Given this list of marker genes KCNB1, RAB6A, AP3S2, MITD1, EHD3, SYT7, SEC24C, MTMR2, BLTP3B, EXOC1 (exocyst complex component 1), EHD4, TRIM23, ARRB1, GH1, TMED5, RAB32, ITGA4, EIPR1, TXLNA, FCGRT, ABCA1, MGRN1, ZFYVE16, PKDCC, MBL2, SLC18A2 (NCBI Gene Id 6571), MAPK3, CALY, STBD1, PIP5K1A, CLEC10A, CLEC4M, CTNNB1, CAPN2, RAB5A, KIAA0319L, SNPH, MTMR9, CMTM6, RIN2, CALM2, ACSL3, GOLGA7, AP3S1, PDLIM7, PIKFYVE, GGA3, CSPG5, GRXCR1, CLCN2, ARL11, ITGAV, FCMR, NEDD4L, PLA2G4E, CD300LF, PRKCG, SYNGR3, GSG1L, INTU, BLZF1, RAB27B, SCAMP2, MON1A, UEVLD, IL4R, IL10RA, YIPF1, OTOF, SCAP, ACHE, OSBPL5, CFTR, PDPK1, ENPP1, SNX30, SNX6, SGSM3, TMCC1, NOTCH1, VPS35L (VPS35 endosomal protein sorting factor like), PRKCB, NSG2, CSK (NCBI Gene Id 1445), LRP4, CSNK1G3, SEPTIN4, SNCG (NCBI Gene Id 6623), GPR151, CD81, AP4B1, NCF4, BAIAP3, BECN1, MAPKAPK2, HPCA, ZFYVE9, CTTN, TMEM63B, RAB11FIP1, LIN7A (lin-7 homolog A, crumbs cell polarity complex component), ADGRE2, CBLB, YIPF6, ERO1B, YIPF7, KIF5A, BLOC1S5, NLRP5, GIT2, RAB13, USO1, FCGR2B, SYNRG, ANO6, SPHK1, RUBCN, PRKAR1B (protein kinase cAMP-dependent type I regulatory subunit beta), HSPG2, VPS13A, DOC2B, AP5S1, FUZ, COPB1, SV2A, MSN, GRK3, TREX1, SYNGR1, VTA1, TRAPPC3L, NCKIPSD, MBTPS1, RAB33B, CUX1, ARF3, PLIN3, STX1A, RAB39B, PLLP, SEC16B, RAB11B, FGR, M6PR, FNBP1, RAB9A, LEPROT, VPS26C, SNX5, SNAP91, SCARA3, PIK3CB, ANXA8, MIR27B, GATA2, VAMP4, NAPA, SIRPG, IFNG, GPC3, RAB40B, SNAPIN, SYT10, EPHA3, STXBP2, NCKAP1L, HEATR5A, TMED6, SLC48A1, LEPR, ATP6V1C1, AGAP2, AP1S3, RAPGEF4, SLC2A4, NEDD4, PTGDR, ARFGAP3, NLGN3, LRRTM2, SEC23IP, DENND1A, ACKR3, PACSIN1, NRG1, CLTA, SCARF1, SNX9, PGAP1, FERRY3, ACTB, NPY, HPS4, TVP23C, C4BPA, DRD2, VAMP7, LIPA, RASEF, PDCD6IP, CEBPE, SPHK2, DENND2A, GTF2H2, LIN7C, CHMP4B, SV2B, ATAD1, ANK1, PRKACA, BRSK1, CLCN3, TMEM50A, STEAP2, TGFB1, RAB31 (RAB31, member RAS oncogene family), RAB9B, RER1, PIP4P2, RAP1B, PLAA (NCBI Gene Id 9373), PCDHGA3, SOD1, CXCL16, DOC2A, DENND10, BET1, VPS37D, MYO1A, OPHN1, P2RY6, GGA2, FCGR1A, CEP19, SMCR8, DIAPH3, AP3M2, VPS50, CORO7, SEC24A, TAPBP (TAP binding protein), STX3, PINK1, FCER1A, PIK3CG, EPS15L1, SEPTIN1, STX10, VPS16, RALA (RAS like proto-oncogene A), RUFY4, SLC4A8, IRAG2, HAP1, RPH3AL (rabphilin 3A like (without C2 domains)), LILRB1, PEF1, LMF1, AP5M1, ERC2, HMGXB4, RAB21, COPE, SNX18 (NCBI Gene Id 112574), CSNK1G2, PLEKHF1, CSNK1G1, RNF139, PIK3CA, SH3BP4, SCFD1, CLCN5, USP33, GABARAPL2, RAB7B, ENDOU, CD47, PTX3, FOLR1, CLTCL1, MTMR4, LRRTM1, VAV1, STARD3NL, GDI2, APOC2, SCAMP5, RGP1, EXOC7, SNX33, DOCK2, APP, SYTL1, PLD2, ATP6V1B2, VLDLR, GRIK5, CAMK1D, CEP83, CUBN, ARRB2, KCNN4, RIMS2 (regulating synaptic membrane exocytosis 2), LLGL1, RAP1BL, PIGR, RASGRP1, COPZ2, GAB2, LAT2, RHOQ, TULP1, RUFY1 (NCBI Gene Id 80230), SFT2D1, ARF6, KIF1C, TM9SF4, PPT1, AP5B1, PPP3R1, COPA, VPS54, TBC1D10C, IGF2R, HTT, FCER2, GOLGA4, STAB1, RP2 (RP2 activator of ARL3 GTPase), CCR2, KIF17, KDELR1, C3, TNK2, MIA2, RHOV, AP2M1, RHOU, AP1M2 (NCBI Gene Id 10053, adaptor related protein complex 1 subunit mu 2), MYO6, EFR3A, RAB34, AP3M1, STX8, ZW10, BCAP29, STX4, COPG1, KLRC2, SCRIB, PRSS12, RAC1, TREM2, CHMP4BP1, SEC22B, CPLX1, EVI5, CCL3, USH1G, CACNA1B, DLL1, KIF13A, PRG4, DCTN1, DYSF, ARHGAP1, NDRG4, TRAPPC1, PIK3R4, SERPINE1, CHMP4C, SQSTM1, GPRASP1, SCARA5, LAT (linker for activation of T cells), LYAR, PSTPIP1, MYD88, CCDC91, PIP4K2A, ANKRD13D, COG2, BLOC1S6, KALRN, PRICKLE1, LDLRAD1, ANKRD13A, TBC1D24, MIR183, SNX8, RAB11A, JAGN1, SLC66A2, PLPP4, VTI1A, BTBD8, ABCA2, H1-1, AP1G1, YES1, APOA5, SNAP23, ACKR4, SCAMP3, AP1AR, SNX4, SORT1, DGKD, MCFD2, ARHGAP25, CRYZL2P-SEC16B, PLA2G3, ZP3, DNM2, CCL8, DENND1C, SEC16A, ARL5B, PIK3C3, LBP, STX6, ATG5, BCR, SLC17A5, RAMP1, C4A (NCBI Gene Id 720), CCL21, SLC9B2, RHOBTB3, CALM3, RTN3, RABGAP1L, SLAMF1, DNAJC6 (NCBI Gene Id 9829), VPS8 (NCBI Gene Id 23355), IRF8, TAFA4 (TAFA chemokine like family member 4), ARHGAP8, FNBP1L, KIT, RSC1A1, RAB1A, LAPTM5, RINL, CADPS, ANXA13, NSG1, ARHGAP27, VPS36, VPS45, TMEM167B, NUMB, BCL2L1, KXD1, RAB40AL, SCARB1, RAB11FIP5, STEEP1, FHIP1B, KLHL20, ADRB3, B2M, ATP8A1, NAPB, CHMP6, SNX1, STON1, MAPKAPK3, NLGN2, CCL19, VPS11, HRAS, HFE, CRYBA1, UBXN6, PLCG2, C4B, TBC1D4, COG8, DGKQ, PRKD1, TSNARE1, SMPD3, GOPC, IL13, MRC2, DBNL, ATP6V0A4, EIF2AK1, GRK2, SYT8, HIP1, PHETA1, HAMP (NCBI Gene Id 57817), EEA1, CDC42SE1, CYTH1, SAR1B, STX2, SPTBN1, WDR81, SYT11, VPS39, FES (NCBI Gene Id 2242), P4HB, STAM2, LMAN2L, CRHBP, ANKFY1, CORO1C, MIB1, ADORA2A, RAB39A, SYTL4, TMED9, KIF1A, ARHGAP44, CAMLG, ATP13A2, SLITRK1, SYP, NRXN1, RAB43, BIN1 (bridging integrator 1), NBAS, TRAPPC6B, CEACAM1, NCDN, PPFIA2, SYNJ2BP, SDCBP, COPG2, AMN, VAMP2, PECAM1, TBC1D10B, LRP6, BRSK2, RAB8A, PRKCA, RAB7A, MFGE8, AP1G2, IL15, PITPNB, MCTP1, SEC22A, WASHC4, RAB22A, ERC1, CACFD1, MICALL1, DNAJC5, CHM, RCSD1, WASHC5, MIR185, BIN2, VPS13B, USP20, JOSD1, TYROBP, RAB8B, C4BPB, IER3IP1, C2CD5, HOOK1, GOSR2, CES1, NCF2, LYVE1, RAB40C, CNN2, DENND1B, RNF126, ELMO1, LYPLAL1, CD22, TMEM108, TSPAN18, VPS51, ENTR1, VPS26B, FGA, LGALS3, UBAP1, NAGLU, GULP1, INSIG1, TBC1D5, VPS41, MON2, WDR44, GSN, YIPF5, OCIAD1, RDX, MYH10, ANK3, ARL1, ELANE, YIF1A, RAB3A, WIPI1, CRP, SYT1, BMP2K (BMP2 inducible kinase), GOLPH3, PLA2R1, LMAN1, MYCBPAP, MIR199A1, CDK5 (cyclin dependent kinase 5), SYT4, AZU1, PTPRJ, VSNL1, SDC4, DRD3, SIRPB1, ADIPOQ, NAPG, STX5, TRAPPC13, SEC31B, CALR, EXOC6, KCNQ3, RAB4B, SSC5D (scavenger receptor cysteine rich family member with 5 domains), MYO1E, SNX12, SYTL2, LRP1, MIR181B1 (microRNA 181b-1), CBL, ARF5, CAV2, CCDC22, VPS52, ARF4 (ADP ribosylation factor 4), GAS6 (NCBI Gene Id 2621), ATG3, PAK1, PLEKHF2, EXOC3L2, SIGLEC1, RAB2A, AP2S1, STXBP6, SGSM2 (NCBI Gene Id 9905), MSR1, SNAP47, AHI1, RASSF9, PACSIN3, CTBP1, CREB3L2 (NCBI Gene Id 64764), UNC13B, EGF, AMPH, CSNK1E, ABL1, RALB (RAS like proto-oncogene B), DAB2, TMEM79, RAB3C, SNX32, TEX261, CPNE1 (copine 1, NCBI Gene Id 8904), DOP1A, ANXA2 (annexin A2), LRP3, DNAJC13, EGFEM1P, ACTR1A, ATP6V1B1, CUL3, ITGB2, CHMP2A, FGG (NCBI Gene Id 2266), CD84, SCRN1, CLASP1, IL4, ARHGAP12, NTF3, RNF220, PIK3C2A, CLTRN, LMBRD1, ABCA13, HLA-F, YIPF4, ZNRF1, RAB11FIP3 (RAB11 family interacting protein 3), VEGFA, FYN, CALCA, TGM2, GOLT1B, RAMP3, NCALD, CLEC16A, VCP, ATP9B, TRAPPC2L, ARL17B, AP3D1 (adaptor related protein complex 3 subunit delta 1), ARHGDIA, CACNB4, ATP6V0A1, TMEM87B, LRP10 (LDL receptor related protein 10), DYNC1LI1, EFNB2, HOOK2, TBC1D17, ARFIP1, SEC13, BNIP1, SIRPA, PRKAA1, ARFRP1, ANXA8L1, WNT5A, TVP23A, HYAL3, ATP2C1, CTAGE1, CORO1A, PLEKHA3, GOLGA2, APOA2, PPP3CA, DNM1, STXBP5L, VTI1B, LGALS3BP, DVL1, CPLANE2, SYS1, LAMTOR1, ARL4C (NCBI Gene Id 10123), CYBA, GATA1 (NCBI Gene Id 2623), ARCN1, RAB3GAP1, TFR2, SLC1A1, RABIF, USE1, SAR1A, SCARB2, COG1 (component of oligomeric golgi complex 1), PTGDS, APPL1, RAB6C, TBC1D14, CADPS2, VPS25, PHETA2, UNC13A, TRPV6, SYT5, FCN2, GOLGA5, LRSAM1, LYSET, ARFGAP2, WDR91, DNM1L, ARC, LRP12, ADGRB1, USP6, LGALS9, KRT18, ACKR2, COPS5, DNM3, ACAP2, SFTPA1, AIF1, CNIH3, CHMP7, PRAM1, NR1H2, LIMK1, PLD1, RAB5B (NCBI Gene Id 5869), AGER, EXOC3, STXBP5, MRGPRX2, SEC31A, WAS, ATP6V1G2, IL2RB, LMAN1L, P2RX7, BLTP1, CNIH1, TBC1D23, RABEP1, LAPTM4B, ATP6V0D1, UNC13C, CDK5R2, FCHO1, MARCO, XKR4, CDC42, ATG14, SLC17A7, RAB26 (NCBI Gene Id 25837), PIK3CD, RARA, NEURL3, GOLPH3L, DOCK1, ARL8B, RIT2, ADORA2B, TPH1, SH3GL3 (NCBI Gene Id 6457), OSBPL2, GRIP1, BVES, RAB2B, PCDH17, TRAPPC4, TSG101, WIPF3, ATP6V1E1, ASGR1, STX17, PLEKHM1, UBE3A, SYTL3, TBC1D20, C2CD6, LMAN2 (NCBI Gene Id 10960), MAGI2, YIPF2, EXOC2, IL1RAPL1, COG4, ASGR2, FSHR, HIP1R, SCFD2, ARFGEF2, CLASP2, MRC1, P2RY1, SUSD4, PRKN, SYT3, ATP6V1G1, WASHC3, UNC119, YKT6, DLG4, TRAPPC8, NRBP1, RIN1, SYTL5, RALBP1, ARF1, EHD1 (EH domain containing 1), SYN1, FCN3, PLS3, SURF4, RAB14, MACF1, ARPC3, SLC17A8, SMAP1, CALCRL, AP3B1, TLR2, MYO15A, WASH6P, NLGN1, KIF1B, ENTHD1, ATXN2 (ataxin 2), EHBP1, YIF1B, AKAP5, HSPA8, KLHL12, CLTB, PTEN, FCGR2C, MAPK8IP3, SNAP29, CCR1, RAB3B, TVP23B, ALMS1, AP2A1, MAPK1, BTK, CLEC7A, RAC2, GCC2, ARL4A, PLEK, SPACA3, SFTPD (surfactant protein D), CHMP4A, INSR, CIDEB, STX16, AKTIP, NEU3, PRKCD, PLSCR1, APELA, CHMP1B, FMN2, NOS2, F2RL1, PLPP3, LYN, LRP8, GAS1, CCDC93, ABCA7, CLN5, FCHSD2, CD300A, SNX3, ATP6V1D, GOSR1 (NCBI Gene Id 9527), SPI1, ELMO3, GGA1, ZFYVE27, CTAGE4, HYOU1, PDCD6, KDELR3, MYO1D, STX11, IFT27, S100A10, EHD2, NOSTRIN (NCBI Gene Id 115677), NEURL1B, CLNK, VPS18, TPRG1L, GREM1, DKK1, CSNK1D, SYCN, LY75, MYO19, CNST, BICD2, AAK1, ILDR1, WNT7A, SNX7, REPS2, VPS33A, TRAPPC12, RAB35, RAB29, EXOC8, ANXA3, PCSK9, TF (transferrin), PIP4K2B, NPC1, CCDC32, BECN2, APOLD1, AP4E1, HPS1, STAP1 (signal transducing adaptor family member 1), FBXL20, MILR1, DENND5A, LDLRAP1, LRPAP1, SNCA, TMED3, ZNRF2, COG3, KDELR2, BBS1, MYLK, CTAGE9, SNX31, TSC2, ARAP3, STAT3, EXOC3L1, ADAMTS9, CD63, PLA2G5, ANKRD50, PRTN3, SH3BP1, NME1, ITGA2, STAB2, CREG1, UBE2O, SPAG9, PACSIN2, STX1B, CDH2, RACK1, WASF2, SYT15, LYST, MYO1G, RAB6D, LRRC7, TRIM27, GRK4, COLEC12, NF2, PI4KB, TFG, RAB30 (NCBI Gene Id 27314), ADRA2A, ERGIC3, PREPL, RNASEK, SDC1, ALS2, MON1B, OPA1, RANGRF, PPFIA3, LRRK2, CAV3, GPR15LG, LGI3, FPR2, TRAK2, RAB3IP, FAM91A1 (NCBI Gene Id 157769), KIF16B, MICALL2, MYO1C, CHMP3, SFT2D3, ATP6V1H, SYT13, ITGAM (integrin subunit alpha M), SYN3, TMEM87A, CXCL8, TNFAIP2, TBC1D2B, SACM1L, ALS2CL, STXBP1, APOA1, SEC23A, ARL14, TAMALIN, HCK, VPS29, MIR205, ITSN1, TMED4, TGFBRAP1, KIF3B, CD160, SH3GL2, SRC, OSBPL1A, BIN3, REST, MAPK15, FOXF1 (forkhead box F1), EXOC6B, AP1M1, RAB3D (RAB3D, member RAS oncogene family), FCHO2, ICAM3, CLEC4F, CTAGE15, EPS15, LEP, ATL2, VPS4A, SEPTIN5, HAVCR1, PICALM, ABCC4, FCGR3A, VAPB, RAP1A, VPS9D1, PEAR1, BLOC1S2, SNX10 (sorting nexin 10), SPON2, SMPD1, VAV3, BET1L, RAB38 (NCBI Gene Id 23682), WDR54, STXBP3, CCL5, WHAMM, TINAGL1, ATP6V1G3, GRIP2, AP4M1, RAB20, SAMD9, AP3B2, IGF1R, PSEN1, C17orf75, NSF, SORCS1, CXCR2, IL2RG (interleukin 2 receptor subunit gamma), SELE, TRARG1, CDX2, STX12, IL15RA, PRRT2, ANXA11, CBARP, SCARF2, DMBT1, SEPTIN8, ADM, ENPP2, RAB36, TRAPPC10, ARL5A, ARL4D, TBC1D8B, MYO1B, RAB4A, AP1S2, LRP5, CYTH3, LIN7B, CD320, CBLL1, NRP1, LILRB4, XKR7, USP6NL, ZP4, SFT2D2, TLR4, APPL2, WDR11, APOC1 (NCBI Gene Id 341), TRAK1, CPLX4, TRAPPC2, TMED1, VPS28, TUSC2, USP46, MIR92B (NCBI Gene Id 693235), MYH9, GNAI2, ITGB1, MYO1H, BRAF, GPR107, PREB, RAB17, TMEM167A (NCBI Gene Id 153339), ATL3, SLC17A6, TRAPPC11, PCLO, ROCK1, GAS7, SLC32A1, VAV2, CASP3 (NCBI Gene Id 836), FLOT1, VPS33B, MARCHF2, CD151, RAB6B, COPB2, EXPH5, LETMD1, MAP2K2, AP2A2, VPS4B, ESYT2, EPHB2, HMGB1, MPPE1, AXL, MAP2K1 (NCBI Gene Id 5604), MFSD2A, ITGAL, NDP, GAK, UBQLN2, TMEM175, RPH3A, ENTREP1, SYNDIG1, RIN3, PPP6C, ADORA1, HGS, CAP1, IL13RA2, AP4S1, TRAPPC2B, SNF8, SGIP1, TRAPPC9, SEC22C, RIMS4, GPIHBP1, TMED10, STON2, WASHC2A, SLC11A1, LDLR, WNT3A, OCIAD2, AP1S1, SYT17, PRKCI (NCBI Gene Id 5584), COMMD1, CHMP2B, RABEPK, FCER1G, PIP5K1C, RSPO1, CPLX2, SHH, RIMS1, BBS2, WASH3P, SNX16, TRAPPC5, EXOC5 (NCBI Gene Id 29024), EXOC3L4, SPG11, DPYSL2, SORL1, WASHC1, C9orf72, SEC24D, ARR3, ICAM5, USP7 (ubiquitin specific peptidase 7), TYRO3, SYT12, MIR20A (NCBI Gene Id 406982), C1orf43, ANXA1, ABL2, FCN1, FCGR1BP, SNAP25, RAB1B, PTPN1, COG5, NR4A3, ATP6AP1, MICAL3, OPTN, ARFGAP1, HEATR5B, APLN, SDF4, SNX2, SPIRE1, TBC1D10A, KLRF2, CTAGE6, PTK2, VPS26A, EMP2, ARFGEF1, REPS1, WASF1, MAGEL2, PLA2G6, CECR2, SEC24B, ITSN2, SEC23B, ANK2, PROM2, ARL3, CD177, MYO5A, MEGF10, ZFPL1, TRAPPC6A, GDI1, SCYL2, COLEC10, RABGGTA, VAMP5, MDM2, TOR1A, TPCN2, SH3KBP1, CTAGE8, STAM, EQTN, ITGB3, CTSL, MYO5C, MVB12A, CDC42SE2, MIR17, PARK7, SCIN, SPIRE2, PTPRC (NCBI Gene Id 5788), MVB12B, CANX, THBS1, BICD1, RBSN, BCAP31, SRPX, COLEC11, TRAPPC3, CNIH2, CD302, SLC18A1, JMJD6, GHR, CLTC, ANKRD13B, MARCHF3, SRCIN1, WDR41, CD163, NKG7, AP2B1 (adaptor related protein complex 2 subunit beta 1), APOC3, RAB12, CHMP1A, PTPN23, ERGIC2, CYTH2, SAG, ARAP1, LDLRAD3, CXCR1, ARL5C, NKD2, TIMD4, RHOJ, TMED7, DEF6, ZDHHC2, MX1, SNX19, STX18, ACE2, MIA3, CDH13, EEF2K, ATP9A, APOBR, PLEKHJ1, CLU, GNAO1, CD14, FGB, DTX3L, FCGR2A, BSN, VPS53, GP2, ABCA12, EPN2, C2, PLXNB2, APLP1, ALOX15, SNCB, CD93, RAB44, RAB11FIP2, HOOK3, CDK16, SNX17, COPZ1, STX7, ANXA2P2, ARL6, TRIP11, CNIH4, BLOC1S1, WASL, RINT1, CRACR2A, RAB41, RUFY2, SYNGR2, CHML, TMEM50B, SOX30, SCYL1, APOE, SYT9, XKR8, PRKCE, STARD3, ELMO2, PPP3CB, MYO18A, VPS35, SYT6, CHMP5, VAC14, ATP2A2, SCN11A, EXOC4 (NCBI Gene Id 60412), EZR, CALM1, RAB37, UNC13D, CLN3, COG6, CLIP3, TMEM115, SYNJ2, PYCARD, GBF1, MYO5B, DENND3, EPN1, DOP1B, LMTK2, GOLT1A, LRP2, LEPROTL1, MICAL1, SYK, SYT2, RABGEF1 (RAB guanine nucleotide exchange factor 1), ATP6V1A, VPS37C, TUB, WASHC2C, PFN2, PEG10, MAPK8IP1, DNER, RUBCNL, FBXO45, RHOB, CD209, CASK, RAB15, LYPLA1, VPS37A, CNTN2, ANKRD27, CHGA, APLNR, DPY30, CLEC9A, DTNBP1, CCL2, CPLX3, VAMP8, NECAB2, CEACAM4 (CEA cell adhesion molecule 4), ERGIC1, CCR7, LMBR1L, CCZ1, LRP1B, VPS37B, AP5Z1, MYO7A, VAPA, SPAST, RAMP2, RABEP2, SLC30A8, VIPAS39, GRIA1, RAB11FIP4, RABGGTB, SNX27, ITCH (NCBI Gene Id 83737), ADRB2, LPAR1 (lysophosphatidic acid receptor 1), INPPL1, IGHE, RAB25, TOM1, ATP6V0C, RAB10 (RAB10, member RAS oncogene family), RIMS3, CCZ1B, ACTG1, ATP6AP2, PICK1, GRP, ANGPT1, MAP4K2, PPP3CC, PLD4, DCLK1, LAMP1, VPS13C, RILP, MERTK, INPP5F, RAB40A, CFP, HMMR, SYNJ1, CARMIL1, NECAP2, SFRP4, XKR6, VTN, NECAP1, MYO1F, EPG5, DPP4, CLINT1, STX19, SH3GL1, RAB27A, VAMP3, S100A13, MTM1, TICAM2, MESD, ATP6V1F, NR1H3, UVRAG, SV2C, MLC1, FKBP15, TMED2, RAB5C, VAMP1, MKLN1, SYN2, MYO7B, GIT1, P2RX1, SCAMP1, CLSTN1, GRB2, GAPVD1, TBC1D21, SPTBN4, DRD4 (NCBI Gene Id 1815), CD36, AHSG, FMR1, CD9, MX2, MST1R, EPN3, MTMR6, LLGL2, SPTBN2, RAP1GAP, BTBD9, ACTN2, CAV1, AP1B1, BORCS7 (NCBI Gene Id 119032), COG7, OLR1, RIC1, PHAF1, TFRC, TRIP10 (thyroid hormone receptor interactor 10), TRIM72, GRIPAP1, here is a description of the gene set: Human Gene Set: GOBP_VESICLE_MEDIATED_TRANSPORT studied in species Homo sapiens A cellular transport process in which transported substances are moved in membrane-bounded vesicles; transported substances are enclosed in the vesicle lumen or located in the vesicle membrane. The process begins with a step that directs a substance to the forming vesicle, and includes vesicle budding and coating. Vesicles are then targeted to, and fuse with, an acceptor membrane.